Given this list of marker genes PRG4, REG1B, SLC2A8, MAN2B1, REG3A (regenerating family member 3 alpha), P4HTM, GALNT18, CLEC17A, LGALS3, CLEC2D, LMAN1L, FUOM, OGFOD2, COL9A1, DPM1, LMAN2L, PPP1R3A, ACAN, CLEC6A, GALNT12, ZG16B, CD209, LMAN1, CD207, PLOD3, PPP1R3F, P4HA1 (prolyl 4-hydroxylase subunit alpha 1), REG4, P3H3 (NCBI Gene Id 10536), FREM1, MLEC, ATRNL1, PRG2, PKD1L3, CRYBG1, SOST, LGALS13 (galectin 13), VTN, KRT1, NCAN, LGALS9B, PYGL, GALNT17, GPI, PFKL, PRG3, PKD1L2, CHODL, GALNT11, CLEC2L, GALNT1, GALK1, CLEC4F, CLEC18A, FCN3, EGLN1, CLEC19A, CD34, SLC2A3, HKDC1, OGFOD1, GALNT9, LGALS7B, CLC, GALNT10, FAM3C, GALNT7, VCAN, SIGLEC14, CLEC18C, ATRN, LGALS2, PLA2R1, SIGLEC11, FBXO2, LGALS1, PPP1R3G, GALNT16, EVA1C, ENPP2, COLEC10, LGALS14, GALNT3, CLEC3A, APCS, ALDOB, EPM2A, MRC2, GALNT13, CD302, ITLN2, DCDC1, ZP3, LGALS8, SIGLEC1, KLRF1, ADGRL1, HLA-DRB1 (major histocompatibility complex, class II, DR beta 1), GALNT4, MAN2B2, AMBP, CRYBG3, NOMO3, UGP2, ADGRL3, SIGLEC6, MRC1, AGL (amylo-alpha-1, 6-glucosidase, 4-alpha-glucanotransferase), CLEC20A, CD33, FCN2, COLEC11, MAN2C1, REG1A, COLEC12, CLEC12A, CD22, FBXO6, C4B, GALNT14, MAN2A1, KLRF2, PLOD2, SORD, CLEC4E, NOMO2, PPP1R3D, ALPK1, KLRG2, MBL2, PPP1R3C, GRIFIN, CHI3L2, GALNT2, SFTPA2, CLECL1P, TALDO1, KLRB1, ACR, LGALS16, CLEC10A, KLRC2, P3H2, G6PD, CLEC2B, GALM, LOXL2, CD72, LGALSL, SIGLEC16, P4HA3, DGCR2, CLEC1A, MAN2A2 (mannosidase alpha class 2A member 2), NOMO1, GBE1, GYS1, GAA, ASGR1, FAM3D, CLEC4G, PHYH, OLR1 (NCBI Gene Id 4973), CLEC11A, SELE, SFTPA1, KLRC1, KLRD1, P4HA2, SIGLEC9 (sialic acid binding Ig like lectin 9), EGLN3, LY75, CEMIP2, SLC2A5, CD69, MGAM, DBH, CLEC18B, PGD, FAM3B, CRYBG2, FCN1, GANC, SELL, KLRC3, POMGNT1, ADGRL2, SIGLEC12, CEMIP, CLEC4A, SIGLEC7, H6PD, EGLN2, GALNT8, RPIA, CALR, CHID1, EMC7, GAL3ST3, CHI3L1, CLEC12B, NPTX2, SIGLEC10, CNTN1, OGFOD3, ZG16, CALR3, GALNT15, HK3, ITIH1, STBD1, ALKBH3, ENDOU (NCBI Gene Id 8909), CLEC4M, IGF2R, GALNTL6, SELP, CLEC9A (NCBI Gene Id 283420), PPP1R3E, KHK, CLEC1B, LAYN, ALDOA, MGAM2, GCK, PKLR, ENG, SFTPD, LGALS4, PPP1R3B, CLN5, CLEC3B, SI, CD248, REG3G, LGALS12, CLEC4C, PTX3, SIGLEC5, ENPP1, CNTN2, CLEC5A, IL2, CD93, FBP1, NECTIN1, CDIPT, GALNT5, CANX, GANAB, HK1, FCER2, SIGLEC8 (NCBI Gene Id 27181), KLRG1 (killer cell lectin like receptor G1), FAM3A, KLRC4-KLRK1, MAG, OS9, ITLN1, GPCPD1, LGALS9C, GALNT6, HLA-DRA, P3H1, CLEC7A, PTN (NCBI Gene Id 5764), PFKM, BCAN, LMAN2, PKD1, HK2 (NCBI Gene Id 3099), PAM, ASGR2, CLEC4D, CLEC2A, GUSB, LGALS9, KLRK1, HEXB, BSG, PLOD1 (procollagen-lysine,2-oxoglutarate 5-dioxygenase 1), CLEC14A, here is a description of the gene set: Binding to a carbohydrate, which includes monosaccharides, oligosaccharides and polysaccharides as well as substances derived from monosaccharides by reduction of the carbonyl group (alditols), by oxidation of one or more hydroxy groups to afford the corresponding aldehydes, ketones, or carboxylic acids, or by replacement of one or more hydroxy group(s) by a hydrogen atom. Cyclitols are generally not regarded as carbohydrates. Human Gene Set: GOMF_CARBOHYDRATE_BINDING studied in species Homo sapiens